Given this list of marker genes PI4K2B, PI4K2A, PIK3C2G, PIK3C2A, PIK3C3, TPTE2, PIK3R4, TPTE, SACM1L, PI4KA, FIG4, VAC14, PIKFYVE, ARF3, INPP5E, ARF1, PI4KB, OCRL, here is a description of the gene set: Synthesis of PIPs at the Golgi membrane studied in species Homo sapiens Human Gene Set: REACTOME_SYNTHESIS_OF_PIPS_AT_THE_GOLGI_MEMBRANE